The following is a description of a gene set: studied in species Mus musculus Mouse Gene Set: MIR_141_3P from publication Chen Y, Wang X (PMID 31504780) Genes predicted to be targets of miRBase v22 microRNA mmu_miR_141_3p in miRDB v6.0 with MirTarget v4 prediction scores > 80 (high confidence targets)., and this is the list of marker genes: Sfpq, Plxna4, Ppm1e, Ppt2, Tshz3, Lrrc8a, Astn1, Etl4, Adck2, Tada1, Supt6, Samd8, Ptpn21, Rnft1, Kcng3, Gucy1a1 (guanylate cyclase 1, soluble, alpha 1), Efcab7, Tbc1d1, Kbtbd4, Hs6st2, Bicd2, Zcchc24, Mapk6, H2az1, Phlpp2, Apbb2 (amyloid beta precursor protein binding family B member 2, NCBI Gene Id 69484), Nrp1, Siglecf, Ythdf2, Ntrk2, Map7d1, Atxn7, Sipa1l2, Pcdh9, Acvr2a, Psat1 (phosphoserine aminotransferase 1), Ttr (transthyretin), Rsad2, Qki, Slc23a2, Fam91a1, Zfp850 (NCBI Gene Id 677048), Trhde, Ptprg, Gls, Ivns1abp, Osbpl6, Klhl28, Etnk1 (NCBI Gene Id 97308), Ankrd44, Reck, Ctbp2, Rab38, Lhx6, Fam168b, Dmwd, Jag1, Slc30a7, B4gat1, Sorbs2, Hook1, Nckap5, Lmbrd1, Plagl2, Cryz, Rdx, Rarb, Prkce, Zdhhc3, Septin11, Ikzf2, Epha2, Fmr1, E2f3, Ppfibp1, Cdk13, Myrip, Mindy3, Sp4, Crlf3, Bend3, Stag1, Mysm1, Atxn1, Tmed9, Lin28b, Stx2, Abl2, Dync1i1, Bivm, Zfp607b, Prtg, Hic2, 4921524J17Rik, Calcr (NCBI Gene Id 209117), Mme (NCBI Gene Id 97098), Zfp606, Slc19a2, Ube3a, Ctnnd2, Hmg20a, Rnf122, Dcun1d3, Osbpl8, Ct55 (NCBI Gene Id 75013), Cfap20dc, Rtl5 (NCBI Gene Id 331474), Gon7, Stat5b, Fkbp5, Ralgps1, Tcf12, Fam227a, Lpar1, Ncoa2, Bahd1, Myt1l, Pphln1, Spry4, Dtwd2, Klf12, Pds5b, Tgfb2, Nufip2 (NCBI Gene Id 78671), Taf12, Gigyf1, Gata6, Pym1, Tiam1, Qser1, Map2k4, Kctd8, Cep43, Adgrb3, Zfp846, Wwtr1, Mapk1, Pou4f2, Thrb, Pakap, Tgfbr1, Akap6, Prkcb, St3gal5, Grb2, Angptl2, Zbtb34, Arl4a, Msantd4, Tmeff1, Tfap2c, Tmem221, Mbnl3, Wdfy3, Kif1c, Epn1, Plscr4, Vsig8, Shisa2, Rheb, Canx, Phyhipl, Ttbk2, Ythdf3, Rb1cc1, Slk, Ezh1, Stxbp5, Mybl1, Msantd2, Urgcp, Tm4sf1, Gcnt2, St3gal3, Fbxl2, Ywhag (NCBI Gene Id 52802), Kif3a, Hs2st1, Cep15, Ctag2, Kcna4, Aldh1a1, Simc1, Htr5a, Cers6, Atg16l2, Entrep2, Fnip2, Il2 (interleukin 2), Tcerg1, Pik3ca, Ifrd1, Mbnl1, Epha7, Crebrf, Bace1, Glcci1, Slain2, Ppfia1, Hephl1, Ccdc177, Mrpl17, Map3k3, Nipal3, Cnr1, Zfp592, Tmem237, Il13ra2, Aco1, Mal2, Ranbp6, Ikzf5, Dusp3, Rbm46, Phlpp1, Myadm, Fat3, Bcap29, Oosp3, Hnrnpf, Spag9, Lbr, Tmem168, Elavl2, Atp6v1a, Pappa, Adck1, Phc3, Cd247, Carnmt1 (carnosine N-methyltransferase 1, NCBI Gene Id 67383), Setdb2, Npas3, Atrnl1, Slc6a14, 9330159F19Rik, Ints8 (NCBI Gene Id 72656), Osbpl11 (NCBI Gene Id 224120), Mtmr6, Plcxd2, Ccne2, Chic1, Src, Cyp26b1, Brd3, Ccp110, Abhd18, Dstyk, Zfp597, Dek, Cdk8, Tfap2b, Dr1, Ash1l, Elmod1, Zeb1, Nr3c1, Kat6b, Gna13, Tnrc6b, Sobp, Zfr, Kif5b, Nfasc, Ero1a, Pdxp, Rtn4rl1, Zeb2, Dolpp1, Rhpn2, Greb1l, Unc5c, Lysmd3, Schip1, Pdgfra, Chd2, Prkacb, Iqschfp, Dnajc13, Cdc25a, Tlcd4, Iqsec1, Cdc14a, Clasp2, Arpc5, Olfm1, Marchf6, Anp32e, Myh10, Ccdc80, Itpripl2, Atad2b, Ppp1r15b, Elk3, Pdcd10, Exoc5, Slc6a9 (solute carrier family 6 (neurotransmitter transporter, glycine), member 9), C3ar1, Ube2r2, Gria4, Ulk2, Camsap2, Sacm1l, Arhgef18, Yaf2, Cyth3, Adpgk, Ntng1, Klf6, Tmem135, B230219D22Rik, Kmt2a, Cfap97, Rnf145, Zyg11b, Dcp2, Slc30a1 (solute carrier family 30 (zinc transporter), member 1), Pgrmc2, Hcn1, Snx27, Ttpal, Cpeb3, Nkd1, Tmtc1, Arfgef3, Vcan, Stk17b, Ak4, Zfp644, Gpc2, Sema6a, Sirt1, Jazf1, Ppm1l, H2az2